The following is a description of a gene set: Segmental accumulation of scar tissue in individual (but not all) glomeruli. species: Homo sapiens Focal segmental glomerulosclerosis Human Gene Set: HP_FOCAL_SEGMENTAL_GLOMERULOSCLEROSIS, and this is the list of marker genes: SLC12A3, GON7, COQ6, NUP133, NUP160 (nucleoporin 160), SMARCAL1 (SWI/SNF related, matrix associated, actin dependent regulator of chromatin, subfamily a like 1), REN, MT-TH, PAX2 (paired box 2), WDR4, LMX1B, MT-ND5, MT-ND4, SGPL1, ARHGAP24, MT-TS2, MAGI2, APOL1, MT-TL1, NARS2, INF2, LAGE3, CLCNKB, NUP85, NPHS1, PLCE1, EMP2, VPS33A, ITGA3, MT-ND6, TP53RK, DAAM2, LAMB2, COL4A3 (collagen type IV alpha 3 chain), NEK8, PTPRO, TRPC6, MT-CO1, NUP37, SLC37A4, NUP107, LAMA5, MTX2, NPHS2, TPRKB (NCBI Gene Id 51002), KIRREL1, MT-CO3, MT-TW, CRB2, NOP10, NUP93, WT1, COQ8B (NCBI Gene Id 79934), GAPVD1, MT-ND1, G6PC1, WDR73, SCARB2 (NCBI Gene Id 950), MYO1E, NUP205 (NCBI Gene Id 23165), SEC61A1, JAG1, ARHGDIA, CD2AP, ANKFY1, ACTN4, DKC1, MT-CO2, COQ2, TBC1D8B, MT-TQ, ANLN (NCBI Gene Id 54443), CLCN5, MT-TF